The following is a description of a gene set: Excessive or long-lasting innate immune responses can be harmful to the host, so negative feedback mechanisms are essential. part of: Interferon Signaling Reactome Pathway: Modulation of host responses by IFN-stimulated genes species: Homo sapiens, and this is the list of marker genes: RIGI, IKBKB, UBE2L6, UBA7, IFI6, IFI44L, HSPA5, ARIH1, HERC5, ATF6, ISG15, TRIM25, CHUK, IFI44, EIF2AK3, IFIH1, FKBP5, IKBKG, IFI27